The following is a description of a gene set: species: Mus musculus Any process that results in a change in state or activity of a cell or an organism (in terms of movement, secretion, enzyme production, gene expression, etc.) as a result of detection of, or exposure to, a hypotonic environment, i.e. an environment with a lower concentration of solutes than the organism or cell. Mouse Gene Set: GOBP_HYPOTONIC_RESPONSE, and this is the list of marker genes: Fbp1, Pck1, Tspo, Slc12a5, Trpv4, Slc12a6, Stk39 (serine/threonine kinase 39), Oxsr1, Mylk, Clcn2, Itga2, Aqp5, Prkg2, Slc4a11